The following is a description of a gene set: from publication Dawson DW, Hong JS, Shen RR, French SW, Troke JJ, Wu YZ, Chen SS, Gui D, Regelson M, Marahrens Y, Morse HC 3rd, Said J, Plass C, Teitell MA (PMID 17260020) studied in species Mus musculus Genes hypermethylated in at least one of the lymphoma tumors of transgenic mice overexpressing TCL1 in germinal center B lymphocytes. Most human lymphomas originate from transformed germinal center (GC) B lymphocytes. While activating mutations and translocations of MYC, BCL2 and BCL6 promote specific GC lymphoma subtypes, other genetic and epigenetic modifications that contribute to malignant progression in the GC remain poorly defined. Recently, aberrant expression of the TCL1 proto-oncogene was identified in major GC lymphoma subtypes. TCL1 transgenic mice offer unique models of both aggressive GC and marginal zone B-cell lymphomas, further supporting a role for TCL1 in B-cell transformation. Here, restriction landmark genomic scanning was employed to discover tumor-associated epigenetic alterations in malignant GC and marginal zone B-cells in TCL1 transgenic mice. Multiple genes were identified that underwent DNA hypermethylation and decreased expression in TCL1 transgenic tumors. Further, we identified a secreted isoform of EPHA7, a member of the Eph family of receptor tyrosine kinases that are able to influence tumor invasiveness, metastasis and neovascularization. EPHA7 was hypermethylated and repressed in both mouse and human GC B-cell non-Hodgkin lymphomas, with the potential to influence tumor progression and spread. These data provide the first set of hypermethylated genes with the potential to complement TCL1-mediated GC B-cell transformation and spread. Mouse Gene Set: DAWSON_METHYLATED_IN_LYMPHOMA_TCL1, and this is the list of marker genes: Cdkn2a, Egr2, Sox3, Auts2, Macrod2, Sox1, Bhlhe22, Slc24a3, Zic3, Ncam1, Gm9767, Irx3, Cyrib, Cadps2, Hmgn1, Prr16, Samd5, Ptprd, Hoxa2, Epha7, Zdhhc5, Hoxd13, Mdga2, Adgrl2, Mtcl3, Fam184a, Rnf180, Medag, Osbpl6, Esr1, Foxd3, Spry2, Ccser1, Tnfaip2, Sox17, Clec16a, Golga5, Tns3, Arhgef26, Gm12688, Pkp4 (plakophilin 4), Tbx18, Ajap1, Pcdh10, Id4, Foxc1, Stk39, Tshz3, Plcb4, Tmem30b, Clvs2, Oprd1, Tmem229a, Evx2, Nrsn1, Foxg1, Klhl29, Ism1, Runx1t1, Fign, Gas1